Given this list of marker genes RPA1, POLD2, RPA2, RFC3, POLD4, POLD1, RFC5, POLE, RPA3, RFC1, APEX1, POLE4, FEN1, PCNA, POLD3, LIG1, POLB, RFC4, POLE2, RFC2, POLE3, here is a description of the gene set: Long-patch base excision repair (BER) can proceed through PCNA-dependent DNA strand displacement synthesis by replicative DNA polymerases - DNA polymerase delta complex (POLD) or DNA polymerase epsilon (POLE) complex. The PCNA-dependent branch of long-patch BER may occur in cells in the S phase of the cell cycle, when the replication complexes that contain PCNA, POLD or POLE, RPA and RFC are available. POLB incorporates the first nucleotide at the 3'-end of APEX1-generated single strand break (SSB), thus displacing the damaged AP (abasic) dideoxyribose phosphate residue at the 5'-end of SSB (5'ddRP). PCNA is recruited to BER sites by APEX1 and flap endonuclease FEN1, and loaded onto damaged DNA by RFC. POLD and POLE in complex with PCNA continue the displacement DNA strand synthesis. FEN1 cleaves the displaced DNA strand with the AP residue (5'ddRP), and DNA ligase I (LIG1) ligates the multiple nucleotide patch at the 3' end of the SSB with the FEN1-processed 5'-end of the SSB. studied in species Homo sapiens Reactome Pathway: PCNA-Dependent Long Patch Base Excision Repair part of: Resolution of AP sites via the multiple-nucleotide patch replacement pathway